The following is a description of a gene set: A soft tissue continuity in the anteroposterior axis between the second to the third fingers that extends distally to at least the level of the proximal interphalangeal joints. Human Gene Set: HP_2_3_FINGER_CUTANEOUS_SYNDACTYLY studied in species Homo sapiens 2-3 finger cutaneous syndactyly, and this is the list of marker genes: WDPCP, FANCF, FGFR2, TBX5, GPC4, SOST, JUP, GPC3, LRP4, DSP, CDH3